The following is a description of a gene set: The establishment of a barrier between endothelial cell layers of the intestine to exert specific and selective control over the passage of water and solutes, thus allowing formation and maintenance of compartments that differ in fluid and solute composition. Mouse Gene Set: GOBP_ESTABLISHMENT_OF_ENDOTHELIAL_INTESTINAL_BARRIER species: Mus musculus, and this is the list of marker genes: Tjp2, Cldn1, Tjp3, Tjp1, Rap2c, Ptprs, Mir874, Afdn (NCBI Gene Id 240024), Fasn, Icam1, Rapgef2, F11r, Myd88